The following is a description of a gene set: studied in species Mus musculus Binding to an apolipoprotein, the protein component of a lipoprotein complex. Mouse Gene Set: GOMF_APOLIPOPROTEIN_BINDING, and this is the list of marker genes: Lpl, Lrp8, Lrp4, Lrp1, Vldlr, Canx, Mapt, Plg, Hspd1, Mttp, Scarb1, Pcsk9 (NCBI Gene Id 230573), Lilrb4b (leukocyte immunoglobulin-like receptor, subfamily B, member 4B), Lilrb4a, App, Abca1, Lrp6, Lipc, Trem2, Lcat